Given this list of marker genes ZFAND5, AASS, DEPDC7, PPARGC1A, PCK1, UGT2B15, PIK3R1, MYLK, GLYAT, GLYATL1, SLC38A2, ADH4, RCL1, DPYS, CYP3A4, MASP2, KLF9, SLC38A4, PON1, PAH, MAT1A, here is a description of the gene set: from publication Villanueva A, Hoshida Y, Battiston C, Tovar V, Sia D, Alsinet C, Cornella H, Liberzon A, Kobayashi M, Kumada H, Thung SN, Bruix J, Newell P, April C, Fan JB, Roayaie S, Mazzaferro V, Schwartz ME, Llovet JM (PMID 21320499) species: Homo sapiens In approximately 70% of patients with hepatocellular carcinoma (HCC) treated by resection or ablation, disease recurs within 5 years. Although gene expression signatures have been associated with outcome, there is no method to predict recurrence based on combined clinical, pathology, and genomic data (from tumor and cirrhotic tissue). We evaluated gene expression signatures associated with outcome in a large cohort of patients with early stage (Barcelona-Clinic Liver Cancer 0/A), single-nodule HCC and heterogeneity of signatures within tumor tissues. Genes under-expressed in hepatocellular carcinoma (HCC) with vascular invasion. Human Gene Set: MINGUEZ_LIVER_CANCER_VASCULAR_INVASION_DN